Given this list of marker genes Nup58, Nup54, Nup93, Nup155, Aaas, Nup210, Ndc1, Seh1l, Nup205, Nup85 (nucleoporin 85), Rae1, Nup133, Nup42, here is a description of the gene set: studied in species Mus musculus This event has been computationally inferred from an event that has been demonstrated in another species.<p>The inference is based on the homology mapping from PANTHER. Briefly, reactions for which all involved PhysicalEntities (in input, output and catalyst) have a mapped orthologue/paralogue (for complexes at least 75% of components must have a mapping) are inferred to the other species. Reactome Pathway: IP3 and IP4 transport between cytosol and nucleus electronically inferred by orthology from the curated human pathway part of: Inositol phosphate metabolism